The following is a description of a gene set: Human Gene Set: HP_ABNORMAL_ODONTOID_PROCESS_MORPHOLOGY Abnormal odontoid process morphology Abnormal structure of the odontoid process, which is a part of the C2 or axis vertebra and forms pivot of the structures forming the craniovertebral junction. The odontoid process is also known as the dens of the axis. studied in species Homo sapiens, and this is the list of marker genes: DLL3, DYM, ARSB, DDR2, IDUA, INPPL1, BGN, GNPTAB, DKK1 (dickkopf WNT signaling pathway inhibitor 1), NMNAT1, RMRP, EXTL3, TRPV4, LONP1 (NCBI Gene Id 9361), RAB33B, IARS2, COL2A1, GLB1, COMP, HES7 (NCBI Gene Id 84667), NFIX, FLNB, LFNG, MESP2, EIF2AK3, ALDH18A1 (aldehyde dehydrogenase 18 family member A1), GALNS (NCBI Gene Id 2588), GUSB, TRAPPC2, FLNA (filamin A), FN1, COG4, FGD1, AIFM1